Given this list of marker genes IL17A, ZNF318, EN1, LEF1, FGF12, IKBIP, PROCA1, RBM5 (NCBI Gene Id 10181), MIR676, HOXA4, LIN28B, ART5, PABPC1L, DBX2, NHERF4, LCN2, GARIN5B, KCNK2, SFTPD, CTRB1, SERPINA9, DCLK3, GPX6, GTSE1, POP7, ROBO1, CPT1C (carnitine palmitoyltransferase 1C), SEZ6L, OPN4, GPR82, ZP1, CIMIP7, HEATR3, MSX1, GPR37, KRT4, SCRT2, MB, VWA2, LRFN4, CIB3, RIMBP3, H2AC15, KLF14, NKX6-3, SLITRK1, RGS6, GAS2L1, CARTPT, MVB12A, RAD51B, ATP13A4, LENG1, GCNT7, EDNRA, ZC3H18, SCRN2, PSAPL1, ACSM1, HHIPL1 (NCBI Gene Id 84439), GSC2, DLK1, KLHDC7A, DUSP9, CLEC2L, SUMO1, SOHLH2, CHST10, CES3, AKT1S1, LRRC8E, CERS3, EIPR1, DKK2, ANKK1, MIR181C, BDKRB2, CREB3L4, DDX51, NRARP, FLYWCH1, FMN2, EFCAB5, TRAM1L1, SLC2A8, SLFNL1, TMEM198, H2AC21, SYT13, PLCH2, PTPN9, MAPK8IP2, FGF4, ADIPOQ, CNTROB, SEMA6A, PRPF40A, SHD, MYL3, SLC35E2A, PCOLCE2 (procollagen C-endopeptidase enhancer 2), DNAJB14, PLA2G4F, MORF4L1, FGFR2, RPUSD4, FNDC11, PGRMC2, ENTPD5, GNPAT, DIPK1C, AHNAK2, FXYD1, POU2AF1, DACT2, PPM1B, MPIG6B, SCAND3, KRT84 (keratin 84), NXPH4, MIR145, NUDT19, CBY3, BLTP3B, CSHL1, UBE2D2, CAPN10, PLEKHA4, SOX13, ITIH3, GOLGA1, GPRIN2, DUSP13B, MIR24-2 (microRNA 24-2), PTK2, MRM3, CCND3, TFF2, MAGEA10, NOP16, DNAH1, AIRE, CCN2, HNRNPR (NCBI Gene Id 10236), CASR, here is a description of the gene set: species: Homo sapiens Dendritic cells (DCs) process and present self and foreign antigens to induce tolerance or immunity. In vitro models suggest that induction of immunity is controlled by regulating the presentation of antigen, but little is known about how DCs control antigen presentation in vivo. To examine antigen processing and presentation in vivo we specifically targeted antigens to the two major subsets of DCs using chimeric monoclonal antibodies. Unlike CD8+ DCs that express the cell surface protein CD205, CD8- DCs, which are positive for the 33D1 antigen, are specialized for presentation on MHC class II. This difference in antigen processing is intrinsic to the DC subsets and associated with increased expression of proteins associated with MHC processing. Genes up-regulated in splenic 33D1+ dendritic cells versus CD8 T cells. Human Gene Set: GSE6259_33D1_POS_DC_VS_CD8_TCELL_UP from publication Dudziak D, Kamphorst AO, Heidkamp GF, Buchholz VR, Trumpfheller C, Yamazaki S, Cheong C, Liu K, Lee HW, Park CG, Steinman RM, Nussenzweig MC (PMID 17204652)